Given this list of marker genes Usp9x (ubiquitin specific peptidase 9, X chromosome), Otud7b, Tnfaip3, Otud7a, Usp28, Zranb1, here is a description of the gene set: species: Mus musculus The removal of one or more ubiquitin groups from a protein as part of a process of ubiquitin-dependent protein catabolism. Mouse Gene Set: GOBP_PROTEIN_DEUBIQUITINATION_INVOLVED_IN_UBIQUITIN_DEPENDENT_PROTEIN_CATABOLIC_PROCESS